The following is a description of a gene set: Human Gene Set: GCGCCTT_MIR525_MIR524 Genes having at least one occurence of the motif GCGCCTT in their 3' untranslated region. The motif represents putative target (that is, seed match) of human mature miRNAs hsa-miR-525* and hsa-miR-524 (v7.1 miRBase). species: Homo sapiens, and this is the list of marker genes: SACM1L, FBXO34, SRGAP3, PRP4K, KPNB1, NACC1, HES1, ASCC2, INHBB, MYCL, CSDE1, EBF1 (EBF transcription factor 1), GGNBP2, TLX3, IER2